The following is a description of a gene set: p130Cas linkage to MAPK signaling for integrins Mouse Gene Set: REACTOME_P130CAS_LINKAGE_TO_MAPK_SIGNALING_FOR_INTEGRINS studied in species Mus musculus, and this is the list of marker genes: Ptk2, Bcar1 (breast cancer anti-estrogen resistance 1), Fga, Tln1, Rap1b, Fgg, Itga2b, Src, Fn1, Rap1a, Itgb3, Vwf (NCBI Gene Id 330420), Fgb (fibrinogen beta chain), Apbb1ip, Crk